Given this list of marker genes Thbs1, Slc27a1, Akt1, Acsl5, Akt2, Abcc1, Acsl6, Irs2 (NCBI Gene Id 384783, insulin receptor substrate 2), Acsl1 (acyl-CoA synthetase long-chain family member 1), Slc2a1, Cd36, Slc27a5, here is a description of the gene set: The directed movement of a long-chain fatty acid from outside of a cell, across the plasma membrane and into the cytosol. A long-chain fatty acid has an aliphatic tail containing 13 to 22 carbons. species: Mus musculus Mouse Gene Set: GOBP_LONG_CHAIN_FATTY_ACID_IMPORT_ACROSS_PLASMA_MEMBRANE